Given this list of marker genes GNAQ, PRSS2, HLA-DRB1, TP53, FGB, CFI (complement factor I), NOTCH1, MYH6, ERAP1, NKX2-5, IL10, IL6ST, TET2, LAMA4, PDGFRA, EPAS1, UBA1, PRKAR1A, TTN, THBD, AEBP1, DMD, PMM2, MYPN, GATA5 (GATA binding protein 5), KIF11, FGG, HLA-DPB1, PLG, TLL1, PML, KCNN4, PIGM, PSEN1, SPINK1, MMACHC, MT-CYB, STAT4, KCNJ3, RAF1, SLC4A1, PPCS, F9, SMAD4, PITX2, PRDX1, KCNA5, LMOD2, KCNJ2, KIF20A, TAFAZZIN, SCN4B, TAF1A, MPL, F2, TPM1, CTRC, CSRP3, KLRC4, F8, KCNK3, PLN, KCNE1, PRSS1, CD46, HLA-DPA1, C4A, CALR, STAT3, LIPA, GATA6, MT-CO3, TNNT2, PSEN2, MEFV, TNNI3, GET3, IDH1, DES, RPL3L (NCBI Gene Id 6123), NEXN, DSG2, LDB3, FGA, CTNNB1, IDH2, PRDM16, F5, HLA-B, NFS1, KCNQ1 (NCBI Gene Id 3784), HRG, PRORP, LPIN1, RFT1, ACVRL1, SERPINC1, CTLA4, RYR1, IL23R, KCNJ5, LMNA, PGM1, CITED2, AGGF1, BMPR2, VEZF1, CCR1, THPO, OBSCN, PROS1, MET, RHAG, STAT5B, PIK3CA, ALG6, TLR4, SERPIND1, HAND2, PRTN3, TNNC1, NPM1, NUP155, PTPN22, MT-CO1, HABP2, MYL4, FHL2, SAA1, CD55, CFH, ACTN2, VHL, SCN1B, TMPO, UBAC2, PROC, SCN5A, MPI (NCBI Gene Id 4351), CFTR, MTRR, IRF2BP2 (NCBI Gene Id 359948), NPPA, FKTN, IL12A, MTHFR, TGFB2, IL12A-AS1, MYH9, BAG5, TXNRD2, ADA2, ENG, CRYAB, ACVR1, FLNC, HBB, CPA1 (NCBI Gene Id 1357), MYBPC3, F12, FCGR2C, AKT1, NUMA1, NABP1, RASA1, SDHA, MYH7, GJA5, JPH2, P4HA2, PDE11A, SGCD, SH2B3, GATAD1, SLC2A10, BCOR, RARA, JAK2, F13A1, HELLPAR, CASR, GATA4, TTR, GDF2, PIEZO1, NLRC4, KCNE2, PIGA, TCAP, RBM20, SCN3B, NKX2-6, ANKRD1, CAP2, IFNGR1, ZBTB16, TBL1XR1, BAG3, DSP, VCL, PTH1R, DOLK, CBS, ABCC9, EPOR, FIP1L1, SCN2B, ACTC1, FAS, TRPV6, here is a description of the gene set: Human Gene Set: HP_ABNORMAL_THROMBOSIS Venous or arterial thrombosis (formation of blood clots) of spontaneous nature and which cannot be fully explained by acquired risk (e.g. atherosclerosis). Abnormal thrombosis species: Homo sapiens